The following is a description of a gene set: Genes containing one or more binding sites for (Tex10) in their promoter regions (TSS -1000,+100 bp) as identified by GTRD version 20.06 ChIP-seq harmonization. Mouse Gene Set: TEX10_TARGET_GENES from publication Yevshin I, Sharipov R, Kolmykov S, Kondrakhin Y, Kolpakov F (PMID 30445619) species: Mus musculus, and this is the list of marker genes: Gm14963, Thrap3, Nrg2, Hmgb1, Ugp2, Cul7, Hsd17b14, Mepce, Fto, Pgm2l1, A230083N12Rik (RIKEN cDNA A230083N12 gene), Crkl, Mtcl2, Txn2, Alyref2, Adcyap1, Tmem198, Btbd3, Get3, Iqank1, Nol8, Susd6, Cops7a, N4bp2l2, Yipf2, Gipc1, Lockd, Gan, Ap5z1, Rpgrip1l, A930029G22Rik, Gmip, 2810013P06Rik, Fau, D3Ertd751e, Dleu2, Ctsd, Rbck1, Hmox2, Hmmr, Sp3os, Tubgcp4, Ankrd6, Gm12980, Lrrc1, Hnf1aos1, Tor1aip1, Ccdc88a (NCBI Gene Id 77927), Arv1, Ppp4r3b, 4731419I09Rik, Neurod4, Mrpl39, Uchl1, Phf12, Spsb4, Tmem201, Lin28a, Sbf1, Gm9530, Ralb, Mfsd4b5, Dlgap4, Adcy9, Thap1, Wars1, Gtf3c6, Isy1, Rpl27a, Supv3l1, Shfl, Stard4, Htra2, Sde2, Bet1l (NCBI Gene Id 80411), Bst2, Gm24016, Ppm1e, Bmp4, Mterf4, Dpysl3, Rex1bd, Dedd, Tax1bp1, Bsx, Mrpl1, Extl3, Ndufs6, Nudc, Matr3, 1600014C23Rik, Smg9, Anapc7, Atp8b1, Ttc13, Nudcd2, Sart3, Rrm2, Kcnb1, Znrf2 (zinc and ring finger 2), 2900009J06Rik (NCBI Gene Id 72887, RIKEN cDNA 2900009J06 gene), 1700057H15Rik, Nprl3, Fbxo42, Pwwp3a, Fam149b, Mreg, Atl3 (NCBI Gene Id 77020), Rcn1, Rps8, Lamc1, Xpo5, Rhoa, Aplp2, Ptprj, Plekha3, Gm10570, Sclt1, Fbxo10, Nrip1, Tmem147os, Mfsd4b4, Vdac1, 4930405A21Rik, Vgf, Eed, Adrm1, Vps26a, Eif4e2, Trmo, Mir7b, Ell, Ppfibp1, Fendrr, Vcpkmt, Rexo2, Synj1, Mir7075, Haus6, Pcbp1 (NCBI Gene Id 23983), Ccdc122 (NCBI Gene Id 71108), Lrp3, Rdm1, Nedd9, Dlgap1, Flii, Lemd2, Dtnb, Adnp2, Sptb, Ggn, Vamp8, Rcbtb2, Hdac1 (NCBI Gene Id 630524), Mtcl1, Rbm6, Rdh5, Ctbp1, Rims2, Has2os, Sp3, Kansl3, Rnf166, Gm35986, Actl6b, 5330439K02Rik, Tmem131, Gatad2a, Dcp2, Rap2a, Ywhaz, Ccdc59, Baz1b, Fzr1, Zfp64, Srsf2, Mab21l3, Pcnx2, Tcta, Pramel13os, Rab30, Slc25a22, Ecpas, Mir8104, Tcf4, Tbrg4, Ccdc97, 5430400D12Rik, Epb41l5, Cul4a (NCBI Gene Id 99375), Mphosph6, Ikbip, Tmem185b, Gprin1, Cntnap5c, Smox, Sec62 (NCBI Gene Id 99913), Trim13, Get4, Rnpep, Ptbp1, Rapgef3os2, Eps15l1, 2010109A12Rik, Frmd4b, Atn1, Etv5, Sf3a2, Car10, Cops4, Fscn1, Nppb, Tmem39a, 1110018N20Rik, Mcoln1, Gm16675, Srrm3 (serine/arginine repetitive matrix 3), Spin1, Lsm1, Izumo2, C630004L07Rik, Purb, Hs3st2, Ncdn, Mras, Tardbp, Recql4, Zdhhc18, AV099323, Dync2i2, Ilf3, Helq, Arhgef2, Mindy1, C130036L24Rik, Cdc25a, Nfxl1, Bnip3l, Rad18, Eef2k, Amfr, Nrf1, Proser1, Mrpl15, Fstl5, Uchl1os, Rprd1b, Gtf3a, Spry2, Slc3a2, Gm10518, Asb7, Glis2, Tmem134, Mrpl40, Zc3h4, Ctnna1, Pot1a, Arid2, Coa6, Ece2, AI480526, Gm20652, Barhl1, Bckdhb, Lrp11, 1700113A16Rik, Sephs2, Clhc1, Vps52, Odf2l, E030042O20Rik, 1110020A21Rik (NCBI Gene Id 76587), Raf1, Ifi30, Slc9a5, Spp1, Rnf13, Ubtf, Coa8, Klf7, Ahdc1, Rybp, Ttc16, E230029C05Rik, Oard1, Otud1, Pym1, Gm16208, Eef1a1 (NCBI Gene Id 13627), Blvrb, Mpc2, Atpsckmt, Tbx3, Cux1, Sugct, Nup85, Dclk2, Rprd2, Glce, Chpf, Sall4, Enoph1, Pef1, 5031415H12Rik, Zfp423, Mir292b, Jarid2, 1600020E01Rik, Rundc3a, Tsen54, Uck2, Lhfpl5, Pigv, Smc6, Prr14, Ccdc92, Tnrc18, Cdan1, Setd5, H4c1 (H4 clustered histone 1), Gadd45g, Kdm3a, Sfswap, Cux2, Ndc1, Scg3, Gnb2, Rpgrip1, Tmco3, Slc25a30, Cebpa, Atxn7l2, Amer3, Armc8, Mtln, Med26, Tmem128, Mrpl2, 4930449I04Rik, Snord55, Nop56, Tbc1d12, Foxj3, Gm3716, Pigm, Lrriq4, Ero1a, Stoml1, St3gal2, Grm2, Scarna17, Drap1, Syt9 (NCBI Gene Id 60510), Ube2d-ps (NCBI Gene Id 76508), Tecpr2, Mettl25b, Mccc1os, Lcorl, Zswim7, Foxn3, Sema4b, Twnk (NCBI Gene Id 94248), Fancc (NCBI Gene Id 14088), Ccdc6, Tomm70a (translocase of outer mitochondrial membrane 70A), Lrwd1, Nucb1, Arid1b, Gm16160, Serping1, Fubp1, Prorsd1, Impdh2, C230096K16Rik, Fat1, Celsr3, Ube2m, Mir3093, Gm7211 (predicted gene 7211), Gm14966, Wdsub1, Hmgn2, Morf4l1, Msl1, Sephs1, Sez6, Hyal2 (hyaluronoglucosaminidase 2), Rps27l, Myc, Nell2, Alg5, Primpol, Dram2, Pcsk7, Patz1, S100pbp, Fam20b, Psmd11, B3gnt7, Ctr9, Mob3c, Ghitm, Kri1, Cdt1, 4933440N22Rik, Dennd5b, Tmem154, Cmc2, Jmjd1c, Laptm4b, Prkaa1, Sfxn2, Taf8, Dhx16, Nfasc, Mrpl34, Tmem60, Mpv17, Svop, Slc25a4, Ptp4a1, Zfx, Gm3764, Oplah, Kif11, Necab2, 2310022B05Rik, Hspb9, Ptk2b, Slc4a3, Polr2m, Gemin7, Myo10, Zfp579, Pigq, Plod2, Ccni, Plec, Dync2h1, Pcmtd1, Slc2a3, Vgll4, Sulf2 (NCBI Gene Id 99203), Hnrnpu, Fastkd5, Hnrnpf, Cartpt, Glipr2, Speg, Tmem199, Rnu11, Gm13830, G430095P16Rik, Leo1, Asap1, Ythdc1, Mllt3, Nr4a1, Schip1, Npat, Cflar, Ier2, Cand1, Erf, Grk4, Cnga3, A430018G15Rik, Ak4, Dnmt3a, Men1 (multiple endocrine neoplasia 1), H2bc12, Drg1, Map3k7, Sh3pxd2a, 1700101I19Rik, Ubox5, Rassf1, Ephb1, Oxct1as, Hmcn1, Scarb1, Artn, Gm11175, Arl3, Rasa2, Gm2453, Pole2, Zfp42, Isg20l2, Csde1, Usp49, Bbc3, 2900093K20Rik, Gm16249, Ube2i, Zfp668, Disc1, Pkn3, Slc16a1, Gm19569, Hltf, Rhobtb3, Pcid2, Mlf2, Sptbn4, Ly6g6c, Cspp1, Cyld, 1700003G18Rik, Ccdc68, Plekhh1 (pleckstrin homology domain containing, family H (with MyTH4 domain) member 1), Zfyve1, Dlgap3, Gm14261, Srrm2 (serine/arginine repetitive matrix 2), Prpf40a, Uqcc2, Tjp2, Kmt5b, Rpusd2, Tsn, Pgbd5, Sfmbt1, Szrd1, Ciapin1, Scap (NCBI Gene Id 94123), Nop58, Aktip, Prdm15, Gpcpd1, Nfe2l1, Adgrl2, Srm, Eloa, Zfyve28, Trim71, Rnft2, 1110004F10Rik, Snx1, Car3, Eif4a2, Ly6g6e, Foxf1, Ahcy, Oser1, Rps19bp1, Ndufaf3, Nav2, Alg13, Hectd1, Letmd1, Cnpy3, Rfc1, 1700045H11Rik, Dynll1, Ccdc102a, Rapgef6, Zfp213, Trp53bp1, Rbm7, Dennd4b, Trappc2b, Acin1, Reps1 (RalBP1 associated Eps domain containing protein), Cinp, Gm12522, Mir290a, Adnp, Atad2b, Pole4, Itgb5, Unc13a, Rrm2b, Senp7, Gm13067, Afg1l, Clstn1, Cic (NCBI Gene Id 71722), Emc7, Tbc1d9, Grip1, Gtf2h5, Foxred1, Tmem80, Pdgfc, Dner, Lonp2, Grid2ip, Oxa1l, Piezo1, Kcns2, Ppp4r3a, Lmln, Ppp1r8, Srrm1, Gm26330, Hspb8, Ankle1, Pgk1 (phosphoglycerate kinase 1), Pus10, Tacc1 (transforming, acidic coiled-coil containing protein 1), Zfp2, Tmem179, Lrrc57, Pik3r2, Gm10941, Usp53, Zfp513, Cmas, Slc25a1, Dgcr6, 2010110E17Rik, Casp3, 1190005I06Rik, Arglu1, Rph3a, Mir1199, Mbd5, Sfrp1, Ap2b1, Erlin2, Rnf121, Cd320, Slc30a6, Golga1, G3bp2, Mycl, Fzd5, Tti1, Pofut2, Srsf11, Slc30a1, Tex14, Slc27a1, Fbll1, Map3k6, Kmt2b, Igf2bp2, AA474408, Rab11b, Rab3ip, Ubxn2b, Guf1, Lgr4, Lins1, Raly, Cpne4, Zfyve9, Lmtk3, C430039J16Rik, Gm16096, Rnf44, Comt, Klf3, Phf13, Lrch3, Snord118, Pphln1, Usp7, Cox16, Ppp1r18, Snw1, Cadps, Cdca7, Aggf1, Etv6, Yif1a, Spcs3, Rpl22l1, Ndufab1, Gm12089, Ndufb5, Slc39a13 (NCBI Gene Id 68427), H2bc22, Nup50, Washc2, Slc25a11, Wtap (WT1 associating protein), Chka, F630040K05Rik, Rnf187, B530045E10Rik, Oprm1, Gm3822, 2500002B13Rik, Ywhae, Cst3, Tph2, Arhgef19, Cbx8, Akap11, Fosl2, Gm3329, Mir291b, Ttll4, Uba6, Ssc4d, Tfcp2l1, Crlf1, Alg10b, H4c6, Sntg1, E130317F20Rik, Pnisr, Tuba1b (tubulin, alpha 1B), Rad50, Srebf2, Id1, Rab34, Platr26, Hcfc2, Tbrg1, Hnrnpa2b1, E2f3, Lsm2, Adss2, Crocc, Actn4, Cacnb3, Gm24452, Slc5a11, Mrrf, Gm16283, Elavl2, Gfpt2, Tmem184b, Cbx7, Gm17484, Fkbp1a, Gm15912 (NCBI Gene Id 115488138), Trmt9b, Ints12, Gm10501, Pank1 (pantothenate kinase 1), Mir1938, Fam168b, Depdc7, Akt1s1, Ptdss2, En2, Ess2, Rspo4 (NCBI Gene Id 77217), Mir5122, Xpnpep3, Plekhf2, Scgn, Tsfm, Poldip2, Gm29707, Fbxo45, Nfe2l2, Nudt19, Dtwd2, Dmrt3, Usp38, Gm26397, 2810032G03Rik, Tm2d3 (NCBI Gene Id 77179), Hnrnpk, Kbtbd2 (NCBI Gene Id 210973), Crlf3, Gm12694, Tsr1, Mtss1, Miga1, Lmf1, Ep300, Dync1li2, Rmi1, Gm13162, Eif2b4, Mtnap1, Nol9, Mfsd11, Tcl1, A130010J15Rik, Sap30, Zfp846, Srebf1, 4933424G06Rik, Gsx1, Abhd16a, Gm32950, Pex5l, Fubp3, Cct5, Gstz1, Fam83h, Rwdd1, Ccdc74a, Spic, Triap1, Srsf10, Snord59a, Mtpap, Dapk1, Tmem11, Ppia, Ppp3r1, Mov10, Zbtb40 (NCBI Gene Id 230848), Ifitm1, Klhl8, Tbc1d4, Paip2, Kbtbd4, Mycbp2, Pim1, Scn3b, Gm23119, Abcc1, Itga5, Gm17344, Mrpl33, Arid3a, Rabgap1, Cutc, Rabgap1l, Spire2, Zfp568, Hspg2, Rnf167 (NCBI Gene Id 74807), Rdh14, Rhot1, Ap3s2, Haus2, 1700104B16Rik, Ccnt1, Tmem9b, B230369F24Rik, 1700123O20Rik, Zxdc, Serac1, Mettl17, Chst12, Spred2, Gemin4, Ep400, Chd2, Mir1932 (NCBI Gene Id 100316690), Upf3a, Rfx4, Polr3b, Ndufaf5 (NCBI Gene Id 69487), Atad2, Rock2, Arl6ip6, Ell2, Sdc4, Mir141, Bcan, Btbd2, Jak3, Topbp1, Tmem38a, Mcts2, Med8, Parp1, Ramac, Tbc1d17, Pcna, Lfng, Tbc1d14, Fry, Ddit3, Entpd5, 2610005L07Rik, Rcbtb1 (regulator of chromosome condensation (RCC1) and BTB (POZ) domain containing protein 1), Cdh1, Bend3 (NCBI Gene Id 331623), Vdac3, Gm26513, Ctbs, H2ac12, Cnpy1, G3bp1, Gapdh (glyceraldehyde-3-phosphate dehydrogenase), 1110025M09Rik, Ralgapb, Dusp4, Macroh2a1, Rwdd3, H2ac6, Creld1, Apaf1, Dcp1a (NCBI Gene Id 75901), Hap1, Actr1b, Ccdc92b, Fbxw5, Gatc, Fbxl19, Bnip2, Ppp1r3e, Mpzl1, Mir320, Phf21b, H2bc4, Scrt1, Cntnap5a, Slirp, 1700016H13Rik, Tbl1xr1, Xndc1, Nr2c2, Phtf2, Psmd3, Syndig1l, Rps27a (ribosomal protein S27A), Sprtn, Dars1, Rfx3, Pde4d, Chchd7, Slc8a2, Ptpn9, Pierce1, Fxyd6, Tomm20, Zfp609, Cep70, Zfp36l2, Xntrpc, Tas1r1, Brwd1, Abhd12, Cep170b, Ucn, Wipf1, Magi1, Gm16124, Notch1, Rbbp7, Nagk, E130018N17Rik, Rbmxl2, Prc1, Prss48, Gm17916, Mbnl1, Gm4419, Map4, Poldip3, Snhg12, Vangl1, Naxd, Maneal, Daam1, Asxl1, Mfsd14a, Dcp1b, Lacc1, Mir3569, Csrp1, Mir1904, Hes6, 2010320M18Rik, Set, Sgpl1, Gm15706, Deaf1, Rdh10, Ube3a, Dnajb11, Fhod1, Acaa2, Zmpste24, Wdr53, Apbb2, Cpsf1, Mapk14, Slc25a33, Smarcd1, Prkar2b, Rab3c (NCBI Gene Id 77005), Msantd5l, Dcun1d5, Mafa, Zbtb45, Ctxn2, Mtif2, Urgcp, Six1, Bod1l, Irf2bpl, Tia1, Me2, Pusl1, Stmn1, Scamp5, Baz2b, Srcin1 (SRC kinase signaling inhibitor 1), Pigp, AU040320, Cul1, Arfip1, Homer3, Mrpl30, Cept1 (choline/ethanolaminephosphotransferase 1), Pik3ip1, Ppm1h, Gins1, Snora16a, Polr3d (NCBI Gene Id 67065), C130060C02Rik, Spring1, Ntn1, Tppp, Atp5f1b, Rnf214, Uaca, Exoc8 (exocyst complex component 8), Lrrc24, 2810402E24Rik, Imp3, Mir132, Rnf122, Uhrf1, Phf5a, Smarca5-ps, Zc3h18, H2bc11, Polrmt, Lrpap1, Nr3c1, Rnf115, Gm26704, Zfp740, Pdpk1, Ctxn1, Tbccd1, Ctu2, Bicdl1, Dnajb14, Mir290b, Zfp646, Mtfr2, Zdhhc20, Epo, Ptprn2, Gm14167 (NCBI Gene Id 102633071), Sez6l2, Lsm12, Plekhj1, a, Scube3, Chek1, Trnp1, Gm14024, Setd7, Rbm4b, Tnip1, Alkbh5, Ppp2r3d, Hrh3, Snx3, Klf11, Nefm, Mysm1, Fgfr1, Kctd20, Cdkl2, Tpd52, Zscan29, Polh (NCBI Gene Id 80905), Cit, Strn3, Sorl1, Srpra, Zmym1 (zinc finger, MYM domain containing 1), Eif4e1b, Ndufb6, Gm15787, Gcnt2, Dcaf15, Gm1070, Atrn, Capns1, Rev1, Bmpr1a, Nsfl1c, H4c16, Tmem191, 1700019D03Rik, Scaf4, Omg (NCBI Gene Id 18377), Nt5c2, Spart (NCBI Gene Id 99725), BC043934, Inafm2, Mir2139, 1700067G17Rik, Mapkapk2, Cdc42ep4 (CDC42 effector protein 4), Col5a1, Adprs, Ammecr1l, Bloc1s1, Nrxn1, Nup133, Sgk1, Zfp319, Eomes, Zfp644, Plag1, Mir124a-1 (microRNA 124a-1), Atad5, 5330413P13Rik, Gt(ROSA)26Sor, Ass1, Zfp710, Hexa, Tpm4, Car7, Zfp574, Setd6, Crmp1, Smim7, Ephb4, Trim2, Gpr19, Lrp2, Timm50 (translocase of inner mitochondrial membrane 50), Spg11, Asic3, St8sia3, Tuba1c (NCBI Gene Id 22146), Mybl1, Gen1, Insyn1, Slc12a8, Srp19, Ehd1 (EH-domain containing 1), Cltc, Fabp3, Wwox, Arpc5l, Inhca, Senp5, Tsr3 (TSR3 20S rRNA accumulation), Polr3c (NCBI Gene Id 74414), Itm2b, D2hgdh, Tbc1d2, Eddm13, Camk2b, Map4k4, Rab3a, Fam169a, Fzd2, Psd (pleckstrin and Sec7 domain containing), Hnrnph1, Plxnb1, Emb, Misp3, Tor1aip2, Snx17, Caskin2, Mir148a, Gm23864, A730017L22Rik, Ebag9, Spred3, Slf2, 4931440P22Rik, Hsp90ab1, Grsf1, Mettl25, Psmb6, Gm10010, Zbtb2, Mrgbp, Acot13, Nde1, Gata4 (GATA binding protein 4), C2cd4c, Atp1b1, Plcxd1, Spred1, Uxs1 (NCBI Gene Id 98712), Rnu12, Trappc5 (NCBI Gene Id 66682), Gm12059, Usp20, Pax5, Slc30a9, Atxn7l3b, Esyt2, Nsmaf, Mrps18c, Irf2 (NCBI Gene Id 16363), Slk, Usp30, Trap1, Gmeb2, Strada, Zfp36, Vps37c, AA465934, 2700078F05Rik, Glra1, Ttll1, 5031425E22Rik, Ajap1, Ptch1, Myl6b, Nop14, Usp14, Dgke, Klc1 (kinesin light chain 1), Hars1, Kcnt1, Cog3, Abraxas1, Dclre1b, Amacr, Frg2f1 (FSHD region gene 2 family member 1), 4930430O22Rik, Psrc1, Tmed2, Trim59, Dennd4c (NCBI Gene Id 99998), Hira, Eno1, Gm25855 (predicted gene, 25855), Kdm1a, Rif1, H4c9, BC005624, Bcat1, 4933431K14Rik, Cplx3, Mettl1, Prdm14, Ptrh2, Gm13655 (NCBI Gene Id 667828), Platr8, Ift46, Hpcal1, Dhx15, Oxsr1, Snord3a, Sp1, Mapk11, Aurka, Hook2, Gm15559, Mmgt2, Ppme1, Uros, Ing2, Elk3, Ncapd2, Zmym4, Trmt61b, Afg3l1, Kpna4, Adgrb1, Rbbp6, Slc39a4, Tubb5, Asb8, Bag4, Tspan5, Dnajc7, Pard6b, Arhgap42, Jpt2, Krt10, Ube2q2, Armc6, Mrpl10, Ldb1, Ap5m1, Incenp, Snord2, 4933439C10Rik, Gpr158, Lrrc8d, Gm57488, Rad23b, Col8a2, Mrpl47, Zfp296, Nkiras2, Kdm4c, Jtb, Snx24, Ppp4c (protein phosphatase 4, catalytic subunit), Exosc8, Csrnp2, Gdap1, Gne, Gm35025, Dnajb4 (DnaJ heat shock protein family (Hsp40) member B4), Edem1, Tbx1, Frs2, Dnaaf9, Msl2, Cirbp, Irx5, Asf1a, Naa30, Ctdspl2, Tomm7, Cdx1, Lpar2, Srd5a3, Pum2, Med12l, Pdss2, Mccc1, A730013G03Rik, Jag1, Zfta, Tex10, Dus1l, Dsg2, Mrps28 (mitochondrial ribosomal protein S28), Ddx56, Gm19710, Cdc42, Rnf5, Ube2l3, Thap12, Auts2, Disp2, Ahcyl1 (NCBI Gene Id 99494), C8g, Ino80, Zfp777, Ric8a, Camk1d (calcium/calmodulin-dependent protein kinase ID), Supt16, Tmem248, Rplp0 (NCBI Gene Id 64336), Mapk8ip2, Timm44, Atp5mc3, Atm, Nr5a2, Zfp330, Nckap1, Nrep, Scg2, Kat6a, C9orf72, Psenen, Nptxr, Slc39a14, Crebzf, Coq3, 2200002D01Rik, Pdlim3, Kcnh6, Ccdc148, Mtdh, Vash1, Dnajc11, Vip, Hif1a, Syce2, Txndc15, B230322F03Rik, Gm23143, Usp10, 2610021A01Rik, Foxh1, Clk4, Ly6e, Smurf1, Gtf2h1, Arid1a, Gtpbp6, Brca2, C2cd2, N6amt1, Klf16, Chtf8, Cbfa2t3, Cd151, Boll, 1700096K18Rik, Itch (NCBI Gene Id 77732), Trim36, Twsg1, Coq9, Ywhaq, Ncbp3 (NCBI Gene Id 97706), Fnip2, Ythdf2, Terf2, Glg1, 6230400D17Rik, Usp47, Stag1, Cobl, Hps5, Ttc21b, Plekha2, Ctbp2, Ube2j2, Gm12976, Chd7, Snora3, Gm11839, Gm9917, Acaca, Suz12, Bmp7, Rps18, Ino80b, Sgsm2, Slc9a1, Sms, Ifrd1, Prmt8, Rbm18 (RNA binding motif protein 18), Cbx3, Mir212, Gas1, Katnal1, Prox1, Zswim6, Fam171a2, Upp1, Otx2os1, Wdr76, Cyb5r4, Rpl37, Notch2, Naca, Ecd, Caprin1, Tmub2 (NCBI Gene Id 72053), Vps51, Zcchc8 (zinc finger, CCHC domain containing 8), Ercc1, Obi1, Specc1l, Rigi, Sugp2, Calb1, Rps23, Ppm1b, Stk17b, 9230114K14Rik, Gm6658, Dbr1, Elovl2 (NCBI Gene Id 54326), Anapc2, Glra2, Stxbp5l, Rps26, Rcor2 (REST corepressor 2), Cysrt1, Gm2990, Psd3, Gbp5, Pold2, Dnlz, Gm6410, Mapk1ip1l, Lyrm2, Tyw5, Gm13034, Gm12974, Rab7, Arl15, Oma1, 4930589L23Rik, Hax1, Nemp2 (nuclear envelope integral membrane protein 2), Hspa9, Cecr2, Ext2, Serinc3, 1700030C10Rik, Rbm43, C330002G04Rik, Kdelr1, Shank1, Tnpo1, Atp6v1b2, Anapc15, Ssbp2, Hp1bp3, Atp5po (NCBI Gene Id 28080), Senp1, Snord14a, Mkrn1, Tmsb10, Nr2f6, Gm13562, Mir5133, Zbtb8a, Wdr25, Akap1, Slc6a6, Sympk, Naa12, Zfp131, Syp, Nrde2, Hsp90aa1, 4833445I07Rik, Golga3, Lrrc46, Myo1b, Tmem123, Ddhd1, Vmp1, Shf, Mageb3, Aven (NCBI Gene Id 74268), Kcnc1, Zfp553, Pipox, Gm26562, Fgd4, Katna1, Cpne9, Tmem260, Mapk1, Gpbp1l1, Sccpdh, Mir7648, Pmf1, Mrps2, Ppp1r26, Ywhah, Tmcc1, Ppp1cc, Dido1, Chrnb2, Gm4189, Mtch2, Tubb6, Scpep1os, Cacna1a, Maea, Oxct1, Pola2, Ube2g2, Psme4, Ttc3, H2ac13, Rab39 (RAB39, member RAS oncogene family), Nup54, Abhd6, Smad1, Las1l (LAS1-like (S. cerevisiae)), Hnrnpa0, Zcchc7, Rps13, Snapc2, Zswim4, Uqcrc1, Pcif1, Smyd2, Gm26885 (predicted gene, 26885), Prdm1, Lamtor2, Slc23a2, Kcnk12, Pex12, Memo1, Brpf3, Mcf2l, Platr22, Rab14, Ddr1, Iqsec1, Lrrc14, Pafah2, Atp1b3, Atg101, Nrxn2, Brd2, Pcsk2os1, Fbxo22, Trh, Dhx32, Zfp384, Tvp23a, Gm5106, Bmpr1b, Akain1, Osr2, Gm7008, Gm40332, Rps11, Rcor1, Armh3, Usp13, 4930467K11Rik, Slc25a13, Appbp2os, Exoc5, 4930558J18Rik, Plekhg4, Agpat1, Gid8, Nfyc, Orc4, Plcb4, 9430091E24Rik, Exoc6b, Dynll2 (NCBI Gene Id 97755), Pfas, Wdtc1, Gtf2e2, H3c10, Rps19, Tank, Spmip7, Klhdc4, Htr5a, Tut4, Dhrs13, Mir7654, mt-Tp, Szt2, Nqo2, Arl6ip4, Myo18a, Etv4, Enpp4, H1f3, Polg, Dap3, Map3k10, Zdhhc2, Phip, Dhps, Bcl7c, Utp4, Bccip, 3110031N09Rik, Vps4a, Gm16046, Amotl2, Rrn3, Add1, Pax7 (paired box 7), Hnrnpdl, P4hb, Gm5225, Dpy19l4, Hexim2, 4921524J17Rik, Pbx4, Mtf2, Celf6, Hoxc13, Gad2, Stx11 (NCBI Gene Id 74732), Cox20, Lrrc2, Calu, Yars1, Pex13, Rab11fip1, Prdx1, Napepld, Ubqln4, D430040D24Rik, Atxn2l, Tpst2, Hsd17b11, Spint1, Atp5f1c, Igsf8, Sec31a, Smim27, Cul5, Kmt5a, Lhx3, Mroh1, Diaph1, Esf1, Dbil5, Wipi2, Pdk1 (NCBI Gene Id 78869), Xpa, Ksr2, Setx, Calm2, Lrrc75a, Snrk (SNF related kinase), Mdc1, Anp32e, Nxph1, Cnnm1, Cenpp (centromere protein P), Tle6, Kiz, Armc1, Gstcd, Eri3, Meis3, Bdnf, Rbpj (NCBI Gene Id 791349), Nppc, Neurog1, Fanca (NCBI Gene Id 52324), Ppp2r5a, Mir707, Mfap3l, Col18a1, Rpl26, Rarg, Mir9-3hg, Hpca, Sdhaf2, Maip1 (matrix AAA peptidase interacting protein 1), Smarcd3, Ogdhl (oxoglutarate dehydrogenase-like), Hoxb3os, Ndufs3 (NCBI Gene Id 68349), Aup1, 1110002J07Rik, Gm25894, Vasp, Pten, Dis3l, A330041J22Rik, Als2, Rspry1, Tdp2, Rcn2, Gnai2, H2bc13, Cnot11, Stx4a (NCBI Gene Id 20909), Tmem79, Gtf3c2, Slc10a7, Gorasp2, Elovl6, Ccnc, Rabggta (NCBI Gene Id 56187), Chic2, Odc1, Ackr4, Mir7036b, D1Pas1, Gm5617, Taf10, Ppp5c, Prlhr, Mplkip, E2f7, Kras, Aco1 (NCBI Gene Id 11428), Nfkbiz, Mir292, Caprin2, Mir205hg, Gm26590, Mrpl43, Alad, Slc33a1, Galk1, Nubpl, Coro1c, Tmem170, B3gntl1, Tbc1d8, Hsf2, Bcl3, Krtcap3, Ric8b (NCBI Gene Id 237422), Ankrd37 (ankyrin repeat domain 37), Ppp1r12a, Mblac1, Rtn4, Lnpep, Paqr4, Mymx, Ctnnb1, 6030445D17Rik, Sbk1, Cmklr2, Nlgn2, Dnai1, Prr11, Pex2, Egfl7, Cdkn2aip, Fut8, Eif1, Errfi1, Arl2bp, Mup6, Eef1akmt3, Lipe, Mitd1, Phaf1, Cacng3, Med19, Thra, Marchf4, Gm29609, Slc15a4, Luc7l2, Gm10244, Mcrs1, Smpd3, Foxa3, Tmem147, Gls2, Vwa8, Rnf14, Prcc, Acap3, Grhl1, Rerg, AF357399, 6820431F20Rik, Rplp2, Zfp580, Cripto, Marchf7, Grin1, Gtf2i, Usb1, Rara, Vegfb, Aip, Eif4g3, Mrpl49, Slc18a3, Gm28535, Sergef, Kank1, Phyh, R3hcc1, Cox15, Nid2, Mrpl45, Ssna1, H2az2, Psmg2, Prpf4b, Ipo7, Wdfy3, Rnf139, Aldh9a1, Sf1, Sertad2, Tspyl1, Kin, Asnsd1, Ap4b1, Hace1, Txnrd2, Uba52, Mir762, Anxa2, Slc17a6, 2500004C02Rik, Itgb3bp, Ttc9b, Ncl, Muc1, 4930547M16Rik (RIKEN cDNA 4930547M16 gene), C2cd3, Bag5 (NCBI Gene Id 74791), Fam163b, Pink1, Nufip2, Asphd1, St13, Dync1li1, Alkbh4 (NCBI Gene Id 72041), Rasgrp2, U2af1l4, H2ac11, Rps20, Gse1, Rabif, Zfp81, Gm25336 (NCBI Gene Id 115485816), Adgrb3, Pkp4, Gm19426, Mir200c, Peli3, Polr2a, Eif4a1, Hars2, Pde4a, Hmgxb4, Rell2 (RELT-like 2), Sbf2, Letm1, Rpl10a, Mrpl48, Etnk2, Fblim1, Prss36, Ptrh1, Gmcl1, Zfp664, Pim3, Ash1l, Nfkbia, Zfp74, Zfp961, Espn, A930032L01Rik, Mettl9